Given this list of marker genes NF1, MAP2K1, BRAF, FBXO11, PTPN11, SOS1, here is a description of the gene set: Human Gene Set: HP_PECTUS_EXCAVATUM_OF_INFERIOR_STERNUM species: Homo sapiens Pectus excavatum of inferior sternum Pectus excavatum (defect of the chest wall characterized by depression of the sternum) affecting primarily the inferior region of the sternum.